Given this list of marker genes GATA6, NEK1, PUF60, PRKACB, DOHH, SUPT16H, GDF1, WDPCP, RAF1, INTU, VPS35L, CDC45, GCSH, IFT56, BRAF, TRIO, IRX5, NR2F2, WASHC5, IFT27, NKX2-5, LONP1, EVC, LZTR1, PRKD1, DNAH9, PLXND1, DEF6, ERCC4, FANCB, RBM8A, EHMT1, CFAP53, DHCR7, TBX1, GLI1, RAB34, HYLS1, ZIC3, EVC2, DYNC2LI1 (dynein cytoplasmic 2 light intermediate chain 1), SMAD2, CFAP45, PTPN11, CIROP, BRD4, PKD1L1, CCDC22, KAT6B, CFC1, GLI3 (NCBI Gene Id 2737), CDH2, NKX2-6, DPYSL5, PRKACA, CCDC32, TBX5, WBP4, ACVR2B, GATA4, KDM6A, FOXF1, CRELD1, MMP21, POLR1A, NODAL, here is a description of the gene set: Human Gene Set: HP_ATRIOVENTRICULAR_CANAL_DEFECT studied in species Homo sapiens A defect of the atrioventricular septum of the heart. Atrioventricular canal defect